The following is a description of a gene set: Genes up-regulated in MCF10A cells (breast cancer) grown at low (mesenchymal phenotype) compared to those grown at high (epithelial, basal-like phenotype) confluency. species: Homo sapiens Human Gene Set: SARRIO_EPITHELIAL_MESENCHYMAL_TRANSITION_UP from publication Sarrió D, Rodriguez-Pinilla SM, Hardisson D, Cano A, Moreno-Bueno G, Palacios J (PMID 18281472) Epithelial-mesenchymal transition (EMT) is defined by the loss of epithelial characteristics and the acquisition of a mesenchymal phenotype. In carcinoma cells, EMT can be associated with increased aggressiveness, and invasive and metastatic potential. To assess the occurrence of EMT in human breast tumors, we conducted a tissue microarray-based immunohistochemical study in 479 invasive breast carcinomas and 12 carcinosarcomas using 28 different markers. Unsupervised hierarchical clustering of the tumors and statistical analysis showed that up-regulation of EMT markers (vimentin, smooth-muscle-actin, N-cadherin, and cadherin-11) and overexpression of proteins involved in extracellular matrix remodeling and invasion (SPARC, laminin, and fascin), together with reduction of characteristic epithelial markers (E-cadherin and cytokeratins), preferentially occur in breast tumors with the basal-like phenotype. Moreover, most breast carcinosarcomas also had a basal-like phenotype and showed expression of mesenchymal markers in their sarcomatous and epithelial components. To assess whether basal-like cells have intrinsic phenotypic plasticity for mesenchymal transition, we performed in vitro studies with the MCF10A cell line. In response to low cell density, MCF10A cells suffer spontaneous morphologic and phenotypic EMT-like changes, including cytoskeleton reorganization, vimentin and Slug up-regulation, cadherin switching, and diffuse cytosolic relocalization of the catenins. Moreover, these phenotypic changes are associated with modifications in the global genetic differentiation program characteristic of the EMT process. In summary, our data indicate that in breast tumors, EMT likely occurs within a specific genetic context, the basal phenotype, and suggests that this proclivity to mesenchymal transition may be related to the high aggressiveness and the characteristic metastatic spread of these tumors., and this is the list of marker genes: BLM (NCBI Gene Id 641), VEGFC, TUBB, RECQL4, ZNF367, PRC1, TUBBP5, TOP2A, CYP2A13, CDCA5 (NCBI Gene Id 256676), LRRC8C, TUBA8, H4C3, STAMBPL1, MCM5, PLCG2, PRIM1, ENO1, GDA (NCBI Gene Id 9615), TFDP1, CRY1, IDH2, RELT, NDC80, SKA3, EIF5A2, TUBA1A, EXO1, PGK1, ENC1, SAPCD2, NT5E (NCBI Gene Id 4907), CORT, CALM3, CCNB1, PLK4, ANLN, RFC3, MCM7, PLK1, CMC2, SERPINE2, CDK2, DSCC1, FHL2, CRLF3, TUBB3, FJX1, CCND1, TACC3, ORC6, MSH2, MCM2, ESPL1, POLD3, ARPC5L, PKMYT1, RRM2, DTL, BRCA1, BARD1, TUBB4B, CDCA7, MKI67, MMP14, TNFRSF12A, PCNA, CEP55, CDK1, UHRF1, H4C11, SMTN, STMN1, SDF2L1, ODC1, TUBG1, ASF1B, HMMR, ECT2, SRXN1, PLAUR, STIL, RAD51B, ENOPH1, KIF11, HILPDA, F3, KNTC1, MSANTD3, RFC5, BUB1, TNK1, YWHAH, CDK2AP1, CCNA2, KIF23, HELLS, RBM14, DHFR, RUNX1, SMIM10L1, YEATS4, TGFB2, MCM3, CDC45, BUB1B, CENPE, FABP5, VCAN, HOXC13, MYBL1, FOXM1, CDC7, FBXO41, MT2A, GMNN (NCBI Gene Id 51053), RTEL1 (regulator of telomere elongation helicase 1), MBOAT7, PLEK2, ANKRD1, UBE2T, RFC4, UGGT2, FGF2, UCK2, BRIX1, COX17, PHLDA1, E2F1, MCM6, H4C2, MCM4, RAD51 (RAD51 recombinase), TIMM10, CENPW, CDC6, EIF1AD, KIF20A, ETV1, CENPU, RFC2, CPT1A, STEAP1, ZWINT, TYMS, TMPO, FBXO5 (F-box protein 5), CKS1B, YRDC, GGCT, BCL2L11, CENPA, FOSL1, NUP155, SERPINB2, CCT4, AGAP1, LRP8, MAD2L1, PHF19, RRS1, ASPM, ARPC1B, POLR3K, DCK, H2AX